Given this list of marker genes HBG2, HSD17B2, ADH1B, RASL12, BMP4, RGCC, FGFR4, INHBB, CYTL1, here is a description of the gene set: from publication Blanco-Melo D, Nilsson-Payant BE, Liu WC, Uhl S, Hoagland D, Møller R, Jordan TX, Oishi K, Panis M, Sachs D, Wang TT, Schwartz RE, Lim JK, Albrecht RA, tenOever BR (PMID 32416070) Genes down-regulated in SARS-CoV-1 infection (MRC5 cells, MOI: 3, 24hpi). species: Homo sapiens Human Gene Set: BLANCO_MELO_SARS_COV_1_INFECTION_MCR5_CELLS_DN Analysis of the transcriptional response to SARS-CoV-2 compared with other respiratory viruses, including MERS-CoV, SARS-CoV-1 (SARS), human parainfluenza virus 3 (HPIV3), respiratory syncytial virus (RSV), and IAV.